Given this list of marker genes Ube2d3, Grem2, Acvr2b, Smad4, Smad7 (NCBI Gene Id 17131), Zfyve16, Tgfbr3, Smad1, Acvrl1, Fstl1, Bmp10, Cer1, Amh, Smurf2, Bmpr1a, Smad6, Smurf1, Inhba, Inha, Bmpr1b, Smad5 (NCBI Gene Id 76327), Ski (ski sarcoma viral oncogene homolog (avian)), Ube2d1, Chrdl1, Bmpr2, Nog, Amhr2, Bmp2, Acvr2a, Smad9, Gdf2, here is a description of the gene set: Signaling by BMP Mouse Gene Set: REACTOME_SIGNALING_BY_BMP species: Mus musculus